The following is a description of a gene set: studied in species Mus musculus Trophoblast cell migration that is accomplished by extension and retraction of a pseudopodium. Trophoblast cells line the outside of the blastocyst. Mouse Gene Set: GOBP_TROPHOBLAST_CELL_MIGRATION, and this is the list of marker genes: Smad2, Ythdf3, Acvr1b, Gja1, C1qbp, Arhgdib, Smad3, Timp1, Mmp12, Fbn2, Itgb3 (NCBI Gene Id 268495), Itgb4, Syde1, Vegfa, Calr, Mmp2, Apela, Nodal, Tgfbr1, Acvr1c, Smurf2, Ago2